The following is a description of a gene set: This event has been computationally inferred from an event that has been demonstrated in another species.<p>The inference is based on the homology mapping from PANTHER. Briefly, reactions for which all involved PhysicalEntities (in input, output and catalyst) have a mapped orthologue/paralogue (for complexes at least 75% of components must have a mapping) are inferred to the other species. electronically inferred by orthology from the curated human pathway Reactome Pathway: RUNX1 regulates transcription of genes involved in differentiation of myeloid cells part of: Transcriptional regulation by RUNX1 species: Mus musculus, and this is the list of marker genes: Cbfb